Given this list of marker genes HK1, PMM1, GMPPA, MPI, PMM2, GMPPB, here is a description of the gene set: part of: Synthesis of substrates in N-glycan biosythesis GDP-mannose is the mannose donor for the first 5 mannose addition reactions in the N-glycan precursor synthesis, and also for the synthesis of Dolichyl-phosphate-mannose involved in other mannose transfer reactions. It is synthesized from fructose 6-phosphate and GTP in three steps. species: Homo sapiens Reactome Pathway: Synthesis of GDP-mannose